The following is a description of a gene set: We previously identified toll-like receptor 4 (Tlr4) as a candidate gene responsible for ozone (O3)-induced pulmonary hyperpermeability and inflammation. The objective of this study was to determine the mechanism through which TLR4 modulates O3-induced pulmonary responses and to utilize transcriptomics to determine TLR4 effector molecules. C3H/HeJ (HeJ; Tlr4 mutant) and C3H/HeOuJ (OuJ; Tlr4 normal), mice were exposed continuously to 0.3 ppm O3 or filtered air for 6, 24, 48 or 72 hr. Affymetrix Mouse430A_MOE gene arrays were used to analyze lung homogenates from HeJ and OuJ mice followed using a bioinformatic analysis. Inflammation was assessed by bronchoalveolar lavage and molecular analysis by ELISA, immunoblotting, and transcription factor activity. TLR4 signals through both the MYD88-dependent and independent pathways in OuJ mice, which involves MAP kinase activation, NF-kappaB, AP-1, and KC. Microarray analyses identifiedTLR4 responsive genes for strain and time in OuJ versus HeJ mice (p<0.05). One significantly upregulated cluster of genes in OuJ were the heat shock proteins (Hspa1b; Hsp70), Hsp90ab1). Furthermore, O3-induced expression of HSP70 protein was increased in OuJ compared to HeJ mice following 24-48 h O3. Moreover, BAL polymorphonuclear leukocytes (PMN) and total protein were significantly reduced in response to O3 in Hspa1a/Hspa1btm1Dix (Hsp70-/-) compared to Hsp70+/+ mice (p<0.05). TLR4 signaling (MYD88-dependent), ERK1/2, AP-1 activity, and KC protein content were also significantly reduced after O3 exposure in Hsp70-/- compared to Hsp70+/+ mice (p<0.05). These studies suggest that HSP70 is involved in the regulation of O3-induced lung inflammation through the TLR4 pathway and provide evidence that HSP70 is an endogenous in vivo TLR4 ligand. species: Homo sapiens Genes up-regulated in comparison of lung tissue from wild type mice versus that from TLR4 deficient animals. from publication Bauer AK, Rondini EA, Hummel KA, Degraff LM, Walker C, Jedlicka AE, Kleeberger SR (PMID 21543283) Human Gene Set: GSE20715_WT_VS_TLR4_KO_LUNG_UP, and this is the list of marker genes: VEGFD, MBNL1, DCUN1D1, DDX5, ADH1C, TMEM100, NOX4 (NCBI Gene Id 50507), ITM2B, ITGA8, SCFD1, ADGRE5, FANCL, GLUD1, TMED10, TNFSF13B, DCTN3, GIMAP4, SAMSN1, GATAD1, TACSTD2, UBE2D3, COPZ2, SEPTIN2, PRKAR2A, IMMT, HSPB1, MS4A8, BTG3, IDH3A, MME, ANXA1, CD302, ATP5F1B, EIF4E, RPL18, CYBB, FPR2, PRKCH, RAPGEF4, MAP2K1, TBC1D15, MR1, ALG14, ANGPT1, ASPN, PDGFA, CALR, WNT2, RPS26, MEF2A, SULF2, MAPK1 (NCBI Gene Id 5594), PTGS2, JAK1, SSTR1, CD53, EPAS1, GOLPH3, CRYAB, SNX2, FAM120A, FABP1, SERINC1, SAR1B, GSPT1 (G1 to S phase transition 1), ARL1, SOD3, ORC2 (NCBI Gene Id 4999), TBX4, CLIC4, RABIF, MTMR6, ITGB1BP1, CSDE1, MXRA8, ANGPTL2, MINDY3, NEDD8, NIBAN1, SNAI2, ACKR2, RBP4, SLC35B1, KCTD10, NTRK2, TMEM168, ANO1, PRPF8, RTN4, SURF4, RNF13, LPP, PLBD2, ATP11C, PIK3R1, LGALSL, TCF21, JMJD8, VMP1, DYNLRB1, GHITM, NPVF, GASK1B, GLMP, SEMA6D, SEMA3E, DDX41, MYO10, APLN (apelin), MARCKS, SPCS2 (signal peptidase complex subunit 2), PRKAR1A, SP7, GPRC5B (G protein-coupled receptor class C group 5 member B), RNF149, TWSG1, NCF1, ANKH, CCN2, FIG4, GOLGA3, TSPAN2, SNAP23, APOOL, TRAPPC13, ANKRD44, PLXNC1, AP3S1, KIAA1191, SERPINH1, UBA3, SERPINB1, RAPGEF6, CD36, CD9, UBL5, LRRC2 (leucine rich repeat containing 2), ABHD17C, TMCC3, CYTH3, RRBP1, RCL1, SLC10A3, FBLN5, SQSTM1, IL2RG, PSENEN, CUL3, HSD11B1, FXYD1, RND3, FBXO8, GATAD2A, LMAN2, TMOD3, DNAJA2, TARDBP, CHST2, RMND1, ITGB2, MEOX2, ZFYVE21, PDGFD, LGALS9B, IFIT3, PARP12, NKAIN1, GNA14, ST13, NT5E, HNF4G, CHMP4C, MAP1LC3B, ALDH3A2, SLC25A6, CNTN1, GPX3, VIM, NCBP2, TM9SF3, SLC6A14, CRIPT, PCOLCE2, ST3GAL2, BGN, GUCY1A1, ARMCX3, HSPA5, SYPL1, LRRC8C, CDKN2C, NPNT, GPR108, COL4A3, GOT1, KRCC1, RANBP1, CPT1A, SLC7A10, TBC1D19